The following is a description of a gene set: species: Mus musculus electronically inferred by orthology from the curated human pathway Reactome Pathway: Glucocorticoid biosynthesis part of: Metabolism of steroid hormones This event has been computationally inferred from an event that has been demonstrated in another species.<p>The inference is based on the homology mapping from PANTHER. Briefly, reactions for which all involved PhysicalEntities (in input, output and catalyst) have a mapped orthologue/paralogue (for complexes at least 75% of components must have a mapping) are inferred to the other species., and this is the list of marker genes: Hsd3b4, Hsd3b5, Hsd11b2, Hsd3b2, Cyp11b2, Hsd3b9, Pomc, Hsd3b8, Cyp17a1, Serpina6